The following is a description of a gene set: Genes predicted to be targets of miRBase v22 microRNA hsa-miR-135a-3p in miRDB v6.0 with MirTarget v4 prediction scores > 80 (high confidence targets). from publication Chen Y, Wang X (PMID 31504780) species: Homo sapiens Human Gene Set: MIR135A_3P, and this is the list of marker genes: LOX, GPR15, RERG, COA6, ZBTB41, CHD6 (chromodomain helicase DNA binding protein 6), LINC02694, SLC39A8 (NCBI Gene Id 64116), HGF, PTBP3, KRTAP5-9, PAIP1, TSPAN2, MMACHC, SEL1L, KCNMA1, EXOC6B, VGLL3, ZNF75D, FANCF (NCBI Gene Id 2188), GRIP1, EP300, GLYCTK, STARD13 (StAR related lipid transfer domain containing 13), ZSWIM6, CCDC15, PPP2R2B, MYO1E, KRT12, RAD51B, XG, ARL5A, C9orf152, TRAK2, DNAJB14, ZNF629